The following is a description of a gene set: Mouse Gene Set: GOMF_PH_GATED_MONOATOMIC_ION_CHANNEL_ACTIVITY Enables the transmembrane transfer of an inorganic ion by a channel that opens in response to a change in proton concentration (pH). species: Mus musculus, and this is the list of marker genes: Asic2, Pkd1l3, Aqp6, Pkd2l1, Asic3, Asic1, Pacc1